Given this list of marker genes Casp6, Lmnb1, Lmna, here is a description of the gene set: Reactome Pathway: Breakdown of the nuclear lamina part of: Apoptotic cleavage of cellular proteins electronically inferred by orthology from the curated human pathway This event has been computationally inferred from an event that has been demonstrated in another species.<p>The inference is based on the homology mapping from PANTHER. Briefly, reactions for which all involved PhysicalEntities (in input, output and catalyst) have a mapped orthologue/paralogue (for complexes at least 75% of components must have a mapping) are inferred to the other species. studied in species Mus musculus